The following is a description of a gene set: ISG15 antiviral mechanism species: Homo sapiens Human Gene Set: REACTOME_ISG15_ANTIVIRAL_MECHANISM, and this is the list of marker genes: EIF4A2, TRIM25, NDC1, NUP85, MX2, EIF4A1, NUP160, KPNA3, NUP54, MAPK3, NUP133, PIN1, ARIH1, EIF2AK2, KPNA2, EIF4E2, RPS27A, NUP214, NUP50, UBA7, EIF4E3, UBE2E1, FLNB, UBE2L6, EIF4E, NUP98, JAK1, NUP153, SEH1L, RANBP2, BECN1 (NCBI Gene Id 8678), NUP37, HERC5, RIGI, NUP107, UBC, NUP58, KPNA1, USP18, NEDD4, UBB, KPNB1, NUP155, NUP43, ISG15, PLCG1, RAE1, TPR, NUP210, AAAS, MX1, EIF4A3, POM121, NUP93, NUP35, NUP205, UBA52, NUP188, POM121C, UBE2N, SEC13, EIF4G3, IRF3, NUP62, KPNA7, STAT1, KPNA4, NUP42, IFIT1, PPM1B, NUP88, EIF4G2, EIF4G1, KPNA5